The following is a description of a gene set: Human Gene Set: HOEK_PBMC_INACTIVATED_INFLUENZA_ADULT_7DY_DN from publication Hoek KL, Samir P, Howard LM, Niu X, Prasad N, Galassie A, Liu Q, Allos TM, Floyd KA, Guo Y, Shyr Y, Levy SE, Joyce S, Edwards KM, Link AJ (PMID 25706537) Systems biology is an approach to comprehensively study complex interactions within a biological system. Most published systems vaccinology studies have utilized whole blood or peripheral blood mononuclear cells (PBMC) to monitor the immune response after vaccination. Because human blood is comprised of multiple hematopoietic cell types, the potential for masking responses of under-represented cell populations is increased when analyzing whole blood or PBMC. To investigate the contribution of individual cell types to the immune response after vaccination, we established a rapid and efficient method to purify human T and B cells, natural killer (NK) cells, myeloid dendritic cells (mDC), monocytes, and neutrophils from fresh venous blood. Purified cells were fractionated and processed in a single day. RNA-Seq and quantitative shotgun proteomics were performed to determine expression profiles for each cell type prior to and after inactivated seasonal influenza vaccination. Our results show that transcriptomic and proteomic profiles generated from purified immune cells differ significantly from PBMC. Differential expression analysis for each immune cell type also shows unique transcriptomic and proteomic expression profiles as well as changing biological networks at early time points after vaccination. This cell type-specific information provides a more comprehensive approach to monitor vaccine responses. Genes down-regulated in peripheral blood mononuclear cell 7d vs 0d in adults after exposure to Inactivated influenza vaccine, time point 7D. Comment: Down-regulated DE RNA transcripts (down >= 1.5x) shared between both TIV-vaccinated donors species: Homo sapiens, and this is the list of marker genes: CDKN1A, CABP5, RNU6-1, ADM, KCNJ15, BATF2, ZMYND15, ANKRD22, H2BC11, OSM, RAB20, IGHV3-13, SDC3, EPB41L4A, MXD1, C2 (NCBI Gene Id 12263), THBD, HBEGF, EREG, LIPN, VNN3P, IGKV1-27